The following is a description of a gene set: This event has been computationally inferred from an event that has been demonstrated in another species.<p>The inference is based on the homology mapping from PANTHER. Briefly, reactions for which all involved PhysicalEntities (in input, output and catalyst) have a mapped orthologue/paralogue (for complexes at least 75% of components must have a mapping) are inferred to the other species. Reactome Pathway: APC-Cdc20 mediated degradation of Nek2A species: Mus musculus part of: APC:Cdc20 mediated degradation of cell cycle proteins prior to satisfation of the cell cycle checkpoint electronically inferred by orthology from the curated human pathway, and this is the list of marker genes: Rps27a, Ube2s, Ubb, Ube2d1, Anapc2, Ube2e1, Ube2c, Anapc10, Anapc15, Mad2l1, Cdc26, Cdc23, Anapc7